Given this list of marker genes RPL11, EEF2, TOE1, RPS15, STK38L, RSL24D1, TRA2A, RPL6, DDAH2, RPL13, SORL1, GALNT3, CHMP1B, PLP2, RPS24, NUP214, EEF1G, BST1, S100A4 (S100 calcium binding protein A4), NR4A1, CNPY3, PRNP, THBD, SRSF3, NR4A2, KLF2, ZFP36, RPS7, INPP5K, HLA-F-AS1, UXT, ELF4 (E74 like ETS transcription factor 4), SNAI1, RPL7A, KRT10, RPL32, RPL27A, DDIT3, RPL36, ICAM3, NSA2, EIF3H, FCN1, MEF2C, RPL22, SECTM1, CX3CR1, RPL30, EIF3L, C15orf39, RPS8, NLRP1, NACA4P, ZXDC, FXYD5, RPL36A, TLR4, TSC22D3, RACK1 (receptor for activated C kinase 1), GPR183, RPL4, BTF3, SFTPB, OASL, TAGLN2, ITGB7, RPL21, TKT, ICAM2, C5AR2, RPL8, IER2, TLE3, EIF4B, F5, MAPRE2, RPL37, FRAT1, MYO15B, RPL10, RPL26, PFDN5 (prefoldin subunit 5), ALOX5, MCUB, KLF3, PDK3, CRISPLD2, FTSJ1, CDK9, RPL7, RPS10, CD244, APOBEC3A, NOP53, HAL, ADD3, HSD17B11, ABT1, ASGR2, S100P, RPL27, LTA4H, SYF2, ELF1, OMG, RPL19, CRTAP, RPS15A, SMARCD3 (SWI/SNF related, matrix associated, actin dependent regulator of chromatin, subfamily d, member 3), ARL4C, RPL10A, RARA, PTK2B, HMGB2, SYN2, PHACTR1, CPED1 (NCBI Gene Id 79974), CD69, IRAG2, RPS29, RPL29, UBA52, FOSB, CD37, GABPB1-IT1, RPS28, POLB (NCBI Gene Id 5423), RPS16, JUNB, CNIH1, RBM15B, CHSY1, FOS, RPL38, FBL, RPS13, RPL31, NACA, TESC, DUSP1, EIF3E, PTP4A1, S100A10, RPS18, NOD2, RPL17, YPEL5, PIK3R1 (phosphoinositide-3-kinase regulatory subunit 1), NEK1, CXCR4, TSSC4, IFITM3, FAU, RPL23A, CSF3R, MYLIP, RPS10P5, LDLRAD4, ZNF394, RIN3, SRSF6, KLF4 (NCBI Gene Id 9314), MTMR11, BPI, SIGIRR, CD101 (CD101 molecule), RNASE2, FAM204A, P2RX1, TLE4, PEX16, RPL35, RPL28, IFITM2, EVI2B, UTS2, RRP12, RPL24, APLP2, SRSF7, RPL35A, RPS11, CRIP1, RPL14, IGFBP7, EIF3F, SNRK, NHERF1, TAF1C, JUND, CTNNBIP1, RPS9, CD300A, ANXA1, TES, PPCDC, MEFV, POLR1D (RNA polymerase I and III subunit D), CHD1, CEBPD, here is a description of the gene set: Human Gene Set: GSE42088_UNINF_VS_LEISHMANIA_INF_DC_2H_DN Leishmania major infected human dendritic cells (DCs) exhibit a marked induction of IL-12 ultimately promoting a robust Th1-mediated response associated with parasite killing and protective immunity. In this study, we utilized Affymetrix Genechips to globally assess the host cell genes and pathways associated with L. major infection during early infection (2, 4, 8, and 24 hrs) in human myeloid-derived DCs. Bioinformatic analyses of the hybridized microarray chips identified genes, represented by 848 unique probe sets, which, when compared to uninfected samples were observed to be significantly differentially expressed by one-way ANOVA. Altogether, the data provide a genome-wide perspective on the transcriptional influences Leishmania species exert within human DCs during early infection, and provides a platform for further investigations toward functionally characterizing candidate genes of importance to the IL-12 based immune response to infections. In the current study, we further investigate the L. major infected DC transcriptional during early time points after infection via microarray analysis. from publication Favila MA, Geraci NS, Zeng E, Harker B, Condon D, Cotton RN, Jayakumar A, Tripathi V, McDowell MA (PMID 24808365) studied in species Homo sapiens Genes down-regulated in dendritic cells: untreated versus 2h after infection of Leishmania major.